Given this list of marker genes Hectd2, Thumpd3 (THUMP domain containing 3), Ddc, Lingo2, Ctso, Ubtf, Pbx2, Zfp410, Muc20, Myc, Mrgprb2, Msantd2, Pcdh8, Npy6r, Gdap2, Kank4, Zcchc4 (zinc finger, CCHC domain containing 4), Abcd1, Slc26a3, Mbd5, Sike1, Ammecr1, Cdkn2aip, Nr4a3, Tpst1, Lrrcc1, here is a description of the gene set: Mouse Gene Set: MIR_3970 Genes predicted to be targets of miRBase v22 microRNA mmu_miR_3970 in miRDB v6.0 with MirTarget v4 prediction scores > 80 (high confidence targets). species: Mus musculus from publication Chen Y, Wang X (PMID 31504780)